Given this list of marker genes Nup205, Nup155, Ndc1, Nup85, Ran, Seh1l, Nup133, Sumo1, Nup93, here is a description of the gene set: Reactome Pathway: Postmitotic nuclear pore complex (NPC) reformation part of: Nuclear Envelope (NE) Reassembly studied in species Mus musculus electronically inferred by orthology from the curated human pathway This event has been computationally inferred from an event that has been demonstrated in another species.<p>The inference is based on the homology mapping from PANTHER. Briefly, reactions for which all involved PhysicalEntities (in input, output and catalyst) have a mapped orthologue/paralogue (for complexes at least 75% of components must have a mapping) are inferred to the other species.